The following is a description of a gene set: Human Gene Set: GOMF_BETA_CATENIN_BINDING species: Homo sapiens Binding to a catenin beta subunit., and this is the list of marker genes: CALCOCO1, RNF220, FOXO4, EP300, ADNP, TBL1XR1, CDH17, AXIN1, CDH2, DVL1, PROP1, AMER1, CARM1, SOX9, CDHR3, DACT2 (NCBI Gene Id 353264), CDH7, AMER2, CDH10, TCF4 (transcription factor 4), CDH24, CDH9, CDH22, GJA1, PRKN, KDM6B (lysine demethylase 6B), PIN1, CDH3, HDAC6, CDHR5, PSEN1, TCF7 (transcription factor 7), CTNNA1, BTRC, TRPC4, SKP1, RORA (NCBI Gene Id 6095), CDH12, PTEN, CDH11, CTNNBIP1, NHERF1, PTPRJ, AMER3 (NCBI Gene Id 205147), GSKIP, SOX30, RUVBL2, KANK1, GRIP1, APC, FOXO3, CDH18, CDH1, MED12, AJAP1, CDH4, CHD8, BCL9, GLI3, CDH23, TCF7L2, CDH19, NHERF2, SPECC1L, AR, GSK3B, BCL9L, PTPRU, SOX17, SMAD3 (NCBI Gene Id 51521), CTNNA3, CTNNA2, SALL1, VCL, DLG5, CDH26, SMAD7, SHROOM2, ASH2L, DACT1, KLF4, CXADR, SUFU (SUFU negative regulator of hedgehog signaling), ESR1, CBY1, NR4A2, NUMB, DCHS1, CDH15, MED12L, PTPRK, CTNND2, CDH5, CDH8, CDH13, DVL3, AXIN2, CDH20, FOXO1, SETD1A (NCBI Gene Id 9739), PXN, TAX1BP3, TREM2, APC2, LEF1, PTPRT, CDH6, LZIC